Given this list of marker genes Bphl, 4933409K07Rik, Pth1r, Maoa, H2bc14, Extl1, Rfc3, H2bc9, Krt2, H2bc3, Guk1, Sirpa, Mgst1, Ltbp3, Casz1, Slurp1, Hsd3b6, Stoml1, Krtap19-1, P3h3, Arrdc2, Ckb, Ndufs7, Acoxl, Nop10, Pecr, Nfil3, Smpdl3b, Calhm5, Slc15a2, Mt2 (NCBI Gene Id 17750), Aamdc, Ss18l2, AW209491 (NCBI Gene Id 105351), Col16a1, Rpp40, Nsd2, Pank4, Akr1c18, Acat1 (NCBI Gene Id 235373), Tmem218, H1f4, Stmn1, H2bc4, Olah, C1qtnf12, Cers4, Dapl1, Doc2g, Bola1, Slurp2, Igfbp5, Awat1, Adh1, Tnmd, Wdr47, Pdlim4 (NCBI Gene Id 54412), Cenpl, Rpain, Trub1, Oas1f, Dbp, Mlh1, Rpp38, Prkcb, Sema3b, Elovl6 (NCBI Gene Id 97061), Tent5a, Slc45a3, Paox, Hsd17b10, Kif2a, Pts, H2bc7, E4f1, Pnpla5, Car2, Hgh1, Plekhh2, Hspb8, Lgals4, Elovl3, Rgma, Pttg1, Krt36, H2bc22, Gas2, Nudt21, Tnfrsf18, Krtap5-2, Scd1, Mmrn1, H2bc12, Mdh1, Amigo1, S100a3, Calm5, Cyp17a1, here is a description of the gene set: species: Mus musculus Expression and function of the oncogenic transcription factor activator protein (AP-1; mainly composed of Jun and Fos proteins) is required for neoplastic transformation of keratinocytes in vitro and tumor promotion as well as malignant progression in vivo. Here, we describe the identification of 372 differentially expressed genes comparing skin tumor samples of K5-SOS-F transgenic mice (Fos(f/f) SOS(+)) with samples derived from animals with a specific deletion of c-Fos in keratinocytes (Fos(Deltaep) SOS(+)). Fos-dependent transcription of selected genes was confirmed by quantitative real-time PCR analysis using tumor samples and mouse back skin treated with the tumor promoter 12-O-tetradecanoylphorbol-13-acetate (TPA). One of the most differentially expressed genes encodes the small mucin-like glycoprotein Podoplanin (Pdpn), whose expression correlates with malignant progression in mouse tumor model systems and human cancer. We found Pdpn and Fos expression in chemically induced mouse skin tumors, and detailed analysis of the Pdpn gene promoter revealed impaired activity in Fos-deficient mouse embryonic fibroblasts, which could be restored by ectopic Fos expression. Direct Fos protein binding to the Pdpn promoter was shown by chromatin immunoprecipitation and a TPA-induced complex at a TPA-responsive element-like motif in the proximal promoter was identified by electrophoretic mobility shift assays. In summary, we could define a Fos-dependent genetic program in a well-established model of skin tumors. Systematic analysis of these novel target genes will guide us in elucidating the molecular mechanisms of AP-1-regulated pathways that are critically implicated in neoplastic transformation and/or malignant progression. from publication Durchdewald M, Guinea-Viniegra J, Haag D, Riehl A, Lichter P, Hahn M, Wagner EF, Angel P, Hess J (PMID 18757399) Mouse Gene Set: DURCHDEWALD_SKIN_CARCINOGENESIS_UP Genes up-regulated upon skin specific knockout of FOS by cre-lox in the K5-SOS-F mice (express a constitutively active form of SOS1 in the skin).